The following is a description of a gene set: species: Homo sapiens Binding to a fibronectin, a group of related adhesive glycoproteins of high molecular weight found on the surface of animal cells, connective tissue matrices, and in extracellular fluids. Human Gene Set: GOMF_FIBRONECTIN_BINDING, and this is the list of marker genes: ITGB3, TNFAIP6 (TNF alpha induced protein 6), LOXL3, ITGA4, THBS1, EPHA1, PLEKHA2, HSD17B12, IGFBP5, LRRC15, SSC5D, CTSL, IGFBP3, CTSS, FBLN1, LILRB4, ITGB1, SDC4, MFAP2, MMP2 (matrix metallopeptidase 2), VEGFA, CTSK, FSTL3, CCDC80, ITGA3, MYOC (NCBI Gene Id 4653), SFRP2 (secreted frizzled related protein 2), ITGAV, IGFBP6, LPA